Given this list of marker genes CHMP2B, AGAP1, EGLN1, RHOB, BAIAP2 (BAR/IMD domain containing adaptor protein 2), MRTFB, RHOA, PRMT8, CTTNBP2, CYFIP1, ITSN1, STRN4, CAMKV, AMOT, PDXP, here is a description of the gene set: Human Gene Set: GOBP_REGULATION_OF_MODIFICATION_OF_POSTSYNAPTIC_STRUCTURE studied in species Homo sapiens Any process that modulates the frequency, rate or extent of modification of postsynaptic structure.